The following is a description of a gene set: Any process that reduces the internal pH of a cell, measured by the concentration of the hydrogen ion. studied in species Mus musculus Mouse Gene Set: GOBP_INTRACELLULAR_PH_REDUCTION, and this is the list of marker genes: Fasl, Tmem106b, Cln3, Lamp1, Slc4a7, Bcl2, Atp6v0d1, Atp6v0c, Slamf8, Car2, Atp6v0a1, Avp, Atp6v0a4, Dmxl2, Slc11a1, Ccdc115, Ube3a, Rab39, Rab38, Cln5, Ttpa, Atp6v1b1, Tmem9, Slc12a5, Slc9a8, Tpcn2, Clic4, Tcirg1, Ppt1, Avpr1a (NCBI Gene Id 54140), Gpr89, Atp6v1b2, Lamp2, Atp6ap2, Slc9a7, Snapin, Car7, Cln6, Creg1 (NCBI Gene Id 433375), Grn, Atp6v0a2 (ATPase, H+ transporting, lysosomal V0 subunit A2), Rab20, Rab7, Dmxl1, Atp6v0d2, Tmem199, Rnasek, Aqp11